The following is a description of a gene set: Genes containing one or more binding sites for (ZNF248) in their promoter regions (TSS -1000,+100 bp) as identified by GTRD version 20.06 ChIP-seq harmonization. from publication Yevshin I, Sharipov R, Kolmykov S, Kondrakhin Y, Kolpakov F (PMID 30445619) Human Gene Set: ZNF248_TARGET_GENES studied in species Homo sapiens, and this is the list of marker genes: RN7SL754P, RPS15AP28, NFILZ, TRPM4, TRAV12-1